The following is a description of a gene set: from publication Yevshin I, Sharipov R, Kolmykov S, Kondrakhin Y, Kolpakov F (PMID 30445619) Mouse Gene Set: MAFA_TARGET_GENES species: Mus musculus Genes containing one or more binding sites for (Mafa) in their promoter regions (TSS -1000,+100 bp) as identified by GTRD version 20.06 ChIP-seq harmonization., and this is the list of marker genes: Cbs, A630076J17Rik, Bcar3, Krit1, Tpr, Cfhr1, Uckl1os, Sgsm3, Mipep, Scn9a, AW209491, 4732440D04Rik, Plekhg1, Fam187b, Tm7sf2, Dtd1, Gm12180, Slc29a2 (NCBI Gene Id 13340), Usp31, Txnl4a, Nup107, Tspan4, Rwdd2b, Smarce1, 4933406C10Rik, Tbca, Fam133b, Gak, Ltbp4, Lrrk1, Zfp282, Utp3, Mapre3, Srl, Celf1, 2700068H02Rik, Kctd6, Rmc1, Gm20753, Ankhd1, Siva1, Trmu, Pole3, Dstn, Aars2, Agpat2, Tysnd1, Arnt, Dynlt2b, Mrtfb, 4833418N02Rik, Edem2, Gm17450, Map2k2, Gm10190 (predicted gene 10190), Ercc3, Tnks2, Prr13, Trmo, Cox18, Ptpru, Zfp963, Pcbp2, Aldh9a1, 2310033P09Rik, Herc4, Dgkz, Eef1d, Ewsr1, Slc35f5, mt-Tp, Itpk1 (NCBI Gene Id 217837), Dazap2, Gsn, Phlpp1, Eva1c, Eif3a, Trim29, Tanc2, Nop58 (NOP58 ribonucleoprotein), Ccdc112, Sar1a, Cnih4, Yes1 (NCBI Gene Id 22612), Apex1, Rnase4, Mir6236, Etv1, Ddhd2, Gm4890, Pde7a, Rps27l, Polr1b, Ctsf, Kctd12, Ccnj, Ndrg3, Itgb1, St8sia5, Prlr, Serinc3, Prdm1, Ccdc88a, Atg2a, 4930598F16Rik, Tmed2, Scrn3, Gm9955, Sri, Denr, Nkiras1, Kbtbd7, Creb1, Fbxl12os, Tppp3, Cggbp1, Memo1, Sertad2, Slc45a4, Phf2, Pde7b (NCBI Gene Id 29863, phosphodiesterase 7B), Txlng, Garnl3, Uts2b, Lrp2bp, Rpl21, Nsmce2, Pskh1, 4930563E18Rik, Mtpap, Xrcc4, Mrps24, Mir3971, Synrg, Ninl, Lmo7, Bcl7a, Ppp4r4, Phospho2, Clk4, Specc1l, Mkln1os, Cdkn2c, Axin2, Stag2, Slco1a4, Fam168b, Chmp4b, Adnp, Nr6a1, Med8, Nrep, Dhodh, D630024D03Rik, Wdr7, Ap2a2, Nfkb1, Mrpl48, Suco, Cnnm3, Rnf157, Mrps33, Fam171b, Hes1, Setd5, Mier1, 9330111N05Rik, Sypl1, Kmt5b, Gm17484, Srebf1, Gm14488, mt-Ts2, Wdr5, Acat2, Septin10, Gzf1, Vps37b, Rnu11, Mlf1, Enc1, Cd47, Rev3l, Tyms, Ptpn3, Gna11, Per1, Rabggtb, AW822252, Alad, Ptprd (protein tyrosine phosphatase receptor type D), As3mt, Rps5, Plscr3, Alkbh2, Rpl22l1, Cmc1, Chaf1b, Gpr146, Gm14963, Gm12758, Llgl2, Nbeal1, Gars1, Mrnip, 0610040B10Rik, Tnrc6b, Ggct, Mynn, Manf, Stk3, Tbpl1, Sowahc, Agl, Kat6a, Dyrk1b, Kiz, Gm7160, Gcc2, Abhd4, C2cd4c, Kntc1, Rchy1, Serp1 (NCBI Gene Id 28146), Brpf1, Snx32, Myo6, Syndig1l, Ttc7, 4933430I17Rik, Pde10a, 2500004C02Rik, Aph1b, Fyn, Ube2f, Cryba2, Kcnab2, Gart, B130034C11Rik, Ccdc127, mt-Th, Gm4285, Ppp2r3a, Fam210b, Phlpp2, Lhx1, D030040B21Rik, Papss1, Aamdc, Kdm2a, Mepce, 1810055G02Rik, Gm7071, Ankrd16, Mcc, Zfand3, Nr2f6, Atl1 (NCBI Gene Id 73991), Znhit2, Gm22203, Rpp25, Pptc7, Tnpo1, 1700019D03Rik, Xrcc3, Pdxdc1, Tmem104, Arrdc3, Mtcl1, Gm11821, Edf1, Mipepos, Bhlhe41, Caprin1, Lsm14a, Arl13b, Trp53inp2, Mir132, Scaf4, Bcl10, Tmed3, 2010320M18Rik, Ins2, Shisal1, Phlda3, Thoc7, Sgo2a, Dnm1, Golga5 (golgin A5), Wrnip1, Snx10, Zbtb7b, Tcea2, Clcn3 (chloride channel, voltage-sensitive 3), Mta2, Cul4b, Gm17399, Eapp, Fbrsl1, Cpne8, Ctxnd1, Nfatc2ip, Prrc2b, Psmg2, Erbin, Rnf128, Rpl37a, 4933417E11Rik, Pigq, Cdk5rap2, Etv5, Mir5130, n-R5s194, Kbtbd8os, Bach1, Faim, B230317F23Rik, Nsd3, Phtf2, Ttc39b, Serbp1, Galc, Mirlet7i, Klf5, Nsa2, Fam117b, Styxl1, Cgn, Mecomos, Gm30648, Birc2, Ttc34, Gins2, Dtnb, Ccdc88c, 1110020A21Rik, Peli1, Zfp652, Foxa2, Psmd5, Ssbp1, Atp1a1, Xpot, Prdx1, Ccdc186, Bcr (BCR activator of RhoGEF and GTPase), Aldh4a1, Ddx5, Adck1, Atxn7l3b (ataxin 7-like 3B), Gt(ROSA)26Sor, Ankib1, Sirpa, Polr2l, Tmem42, Ago2, Rab33b, Atp6v0a1, Fpgs, B3galt2, Chid1, Lonp2, Mex3b, Shprh, Tspan14, 4933427D14Rik, Mir5133, Rbl2, Snx5, Rb1cc1, Arf6 (NCBI Gene Id 11845), Mrpl2, Prob1, Rnft2, Cacnb2, Puf60, 2500002B13Rik, Chd6, Trerf1, Tmem147, Ift46, Mgme1, Zfp213, Snx3, Arl3, Ss18l2 (SS18, nBAF chromatin remodeling complex subunit like 2), Lamp1, Tcp11l2, Cdk12, Ergic1, Unc50, Gale, Ankrd12, Rad51b, Dusp23, Kdm5b, Jpt2, Anapc10, Adam10, Adgrg1, Pgls, Cnrip1, Josd2, Gm34086, A830018L16Rik, Cirbp, Gm32950, Cpm, Nat9, Mir3069, Gm37885, Stambpl1, Tubgcp2, Cinp, Med30 (NCBI Gene Id 70303), Asl, 1700023H06Rik, Gm5113, Slitrk6, Osgin1 (oxidative stress induced growth inhibitor 1), AI480526, Wfs1, Ythdf2, Rell2 (NCBI Gene Id 70794), Rab6a, Cabp1, Uckl1, Zcchc2, Snord70, Nr4a1, Dnai1, Mrm1, Icmt, Ube2ql1, Flvcr1, Idh2, Slc16a6, Spring1, Secisbp2, H4c1, Slx4ip, Mmaa, Gopc, Scrt1, 2310026I22Rik, Mir9768, Nop2, Rpl21-ps3, Golga4, Iapp, Gm37254, Kdm3a, Coro2b, Coasy (Coenzyme A synthase), Add3, Psmd1, Dennd4b, Aifm1, Trap1, Mapk8, Rasd1, Anapc16, Abce1, 1700069B07Rik, Eaf2, Zcwpw1, Malat1, Lrrc8b, Ndufaf8, Fam229b, D930007P13Rik, Dagla, Osgep, Dnajc3, Gm10244, Rps3a1, Map4k4, Rrm2b (ribonucleotide reductase M2 B (TP53 inducible)), Pabir1, Gm15545, Slc10a7, Ass1, Zfp740, Lifr (NCBI Gene Id 319661), Fosl1, Smarcc1, Casc3, Pgrmc2, Mvk, Lpin1 (NCBI Gene Id 50494), Gm12762, Tlcd4, Nanos1, Zfp426 (NCBI Gene Id 72998), Il13ra1, Dnpep, Rtn4, Irgq, Spryd3, Pgs1, Map2k4, Erg28, Tmem106c, Upf1, Fhit, Rapgef1, Txnrd1, Exosc3, Rpl14, Ehd3, Eif4e, Tcf4, Epc1, Sesn1, Sbf2, Rnf139, E2f4, Snx11, Mir215, Nlrp4b, Mrs2, Creg1, Sf3a2, Nol12, Hmbox1, Snord45c (small nucleolar RNA, C/D box 45C, NCBI Gene Id 100217425), Ica1, Crebrf, Kif5c, Tmem167b, Id4, Akt2, Macrod2, Hspd1 (NCBI Gene Id 15510), Cherp, Chst12, App, Zkscan2, Slc35e1, Ttll5, Nsun3, Arhgap26, Fam114a2, Ctsl (cathepsin L), Cep95, Prmt3, 4933406I18Rik, Pspc1, Lcorl, Atg5, Strada, Eif4b, Zfp235, Otud6b, Gm26306, Rsrp1, Mmab, Pde4dip, E230016M11Rik, Rpl9, Elf2, Oxld1, Prpf40b, Mfap3l, Msantd5l, Yipf6, Mtmr6, Bicdl1, Poc1b, Fstl3, Cdc37, Gm17344, Hspe1, Pusl1, Wipi1, Cpeb4, Sphkap, Dnai4, Reep2, Swi5, Mecr, Macir, Tex261, Bcl2l11, Eif3d, Zfp146, Ubr2, Ccnl2, Txndc11, Lasp1, Mafb, Gng5, Hapstr1, Jtb, Bod1l, Ubr4, Rcan1, Mob1a, Foxo6, Nutf2, Pik3r1, Tmem138 (transmembrane protein 138, NCBI Gene Id 76664), Polr3e, Mettl15, 1700007L15Rik, Cep85, Aff1, Ipp, Washc5, Nanp, Cdc73 (NCBI Gene Id 96910), Csn3, Cbx3, Rhoq, Gm15564, Kpna3, Pabpc1, Kif18a, Fads2, Nptxr, Fnbp1l, Gnb1, Zbtb7a, Tsc22d2, Snx30, Rad23a, Ppp3r1, Exoc5, Gm11251, Trim46, Mgat5, Gm17435 (predicted gene, 17435), Plcb1, Pom121, Ascc2, Ints9, Map3k4, 4931406C07Rik, Tsc22d1, Krtcap2, Cfap418, Cdc42bpb, Iqgap2 (IQ motif containing GTPase activating protein 2), Spen, Ky, Stag1, Sema6d, Jup, Gm15816, 4930480C01Rik, Map4k5, Actr3, Rtn3, Mllt3, Lacc1, Rpl15, Ccdc122, Eloc, Spata31e2, Gcsh, Cltc, Pja2, Spcs3, Per2, Srrm2, Atp1b1, Gm10961, Gm12915, Ascc1, 4732491K20Rik, Fmo1, Taf1b, Nsfl1c, Mcf2l, Rock2, Usp1, Cyth1, Ttc8, Skic8, Map2k7, 4930449I04Rik, Fam219a, Phf3, Bcl7b, Snip1, Ttpal, Phyhipl, Arhgap35, Entrep2, Ndor1, Lrrfip1, Pkdcc, Usf2, Cdca2, Tmem106b, Isl1, Urb1, Egln2, Tomm20, Adh1, Atp4a, Spaca6, Crcp, Ksr1 (kinase suppressor of ras 1), Rbck1, Mapk8ip2, Marchf3, Cacna1a, mt-Tl2, Lrba, Atxn2l, Capns1, Arf4os, n-R5s88, Sgsh, Atp5f1a, Tm9sf2, Mpv17l, Ncoa3, 2300009A05Rik, Plce1, Fras1, Tex2, Mars1, Eif2a (eukaryotic translation initiation factor 2A), Zdhhc4, Man1c1, Slain2, Gm16759, Hbp1, D130020L05Rik, Dgat1, Glb1l2, Oser1, Hsdl1, Cd164, Scg2, Qrich1, Csrnp2, Hacd3, Hadhb, Norad, Arpc2, Zfp62, Gm26123, Spast, Rab8a, Lss, Cyb5d1, Zfp335os, Ddx3x, Usp6nl, Ndufs4, Szt2, Ttc9c, Acap3, Alg2, Gdi2, Sugp2, Blmh, Fbxo7, Brd4, Gm22043, Herc1, Car7 (carbonic anhydrase 7), Lsr, Ahdc1, Hyi (hydroxypyruvate isomerase (putative)), Ppp1r8, Bsg, Usp32, Mettl21a, Snhg15, Comtd1, Zfat, Dhcr24, Rdx, Gm4189, Gm19409, Cyp51, Ccser2, Rfc5, Rai14, Atad2b, Lrp12, Gm16364, Rogdi, Zbtb2, Ypel3, Lactb2, Adrm1, Sfxn2, Acin1, Zfp318, Msl2, Snora9, 4933408N05Rik, Naa38, Tmem203, Ttll13, Col2a1, Ap5m1, Lmna, Cnot6, Gm10222, Samd4, Cdk4, Polr3h, Laptm4b, Rara, Ctnna3, Pbx3, Coa5, Gfm2, G6pc2, D5Ertd579e, Gpcpd1, Dip2c, Dipk2a, Mapkap1, Nudt9, Tlcd3a, Zc3h14, Pdxk-ps, Tube1, Ube2e3, Rab23, Mir148a, Txndc17, Nphp4, Ptov1, Phf13, Shld2, Tdrd7, Foxj2, Ccnh, Rock1, mt-Nd5, Stat5a, Arhgap22, Timm22, Camsap2, Ube2e1, Psmc5, Tigd5, Fbh1, Dennd4a, Dnaaf1, Armc6, Tph2, Cog2, Dtwd2, Rnf170, Ap5b1, Mir423, Gm12711, Gm24175, Dazap1, Spg7, Wtap, Ftsj3, Tipin, B4galt7 (beta-1,4-galactosyltransferase 7), Gm37450, mt-Nd6, Ost4, Tspan15, Fgd1, Taf1d, A330035P11Rik, Gm9967, Nme4, Gpd1l, Zfp768, Hibadh, Ero1b, A930006L05Rik, Slc15a4, Cep76 (NCBI Gene Id 76151), Rimoc1, Hnrnph3, Arf3, Arf4, Gm16283, Yif1b, Rgs7, Abhd3, Ptprj, Ociad1, Cspp1 (NCBI Gene Id 72327), Aup1, Rab3gap1, mt-Te, Srsf2, Hdac3, Eid2b, Capn7, Preb, Rimbp2, Oxr1, 6030458C11Rik, Mphosph8, Dock8 (NCBI Gene Id 76088), Osbpl5, Sec61b, Nipsnap2, Setd3, Hnrnpf, Vapb, Plbd2 (phospholipase B domain containing 2), Hsf4, Trmt13, Tasor, Cdc37l1, Vps29, Elmo2, Snord37, Nt5c3, Uchl5, Zdhhc20, Rplp2, Tepsin, Coq10b, Spry4, Sdha, Lyplal1, Gpsm2, Gm15860, Tmem131l, Fgl2, Arsa, Tmem170, Pip4p1, Spata1, Lpcat3, Fam83d, Gm15417, Midn, Stard3nl, Tmem147os, Mkrn1, Syne2, Glce, Tm2d2, Tbc1d16, Ulk2, Gm9929, Map3k7, Trp53i13, Ro60, Abhd2, Cers6, Agbl5, Abcg1, Gpr12, C330013E15Rik, Gins3, Ang, Plekhj1, Gm26293, Pkn2, BC043934, Golgb1, Emc1, Lrrc20, Pik3r2, Alkbh5, A430078I02Rik, Mxd1, Zfp653, Piezo1, Otud1, Npr1, Dnaja1, Psma3, Kmt2a, Rab3gap2, Nkx2-2 (NCBI Gene Id 228734), Mir30a, Usp2, Tor3a, Kif20b, Gm15728, Rwdd1, Zdhhc21, Limk2, Ghitm, Zfp398, Cul2, Odr4, Ing5, Slc33a1, Atf6, Htra2, Taf12, Hopx, Tbk1, 2900093K20Rik, Naglu, Ehd1, Pdcd2, Impdh1, Xpc, Son, Ppp2r5d, Lsm3 (NCBI Gene Id 70029), Kir3dl2, Gm25794, Glud1, Apba1, Pnrc1, Zbtb24, Gprin1, Fam222a, Ppp6r3, Cnih1, Mdh2, Hrh3, Hadha, Nsmaf, Rbpj, Mecom, Itgb5, Arhgap39, Gm10421, Tbcc, Ablim1, 1700010B13Rik, Nr1h4, Prmt9, Srsf11, Mfsd14a, Kdsr, Zfand5, Mideas (mitotic deacetylase associated SANT domain protein), Zfp839, Zfp764l1, Snapc3, Vgll4, Limch1, Ccdc137, Gtf2h1, Bcap31, Gnl2, Patz1, Zfp637, Ss18l1, Polr2b (polymerase (RNA) II (DNA directed) polypeptide B), Hook3, H4c8, Rufy3, Zfp148, Hsp90aa1, Dcun1d3, Kdm3b, Atad3a, Btrc, Atp6v1b2, Saysd1, Esco1, Gm15712 (predicted gene 15712), Mcrs1, Cfap97, Tead1, Rbbp6, Baz2b, Sgo1, Exoc4, Wdsub1, Ap1g1, Gm8357, Fos, Dnajc14, Gm10614, Spsb4, Prl7a1, Commd1, Fhod3, E130307A14Rik, Bbc3, Cyb561a3, Nsun4, Smim1, Syncrip, Ccne1, Ercc6l2, Slain1, Csnk1d, Atp8a1 (ATPase phospholipid transporting 8A1), Naa12, Pla2g6, Rad9b, Galk2, Marchf7, Rpl21-ps7, Rhbdd3, Tmtc2, Mfsd6l, 4931414P19Rik, Papola (NCBI Gene Id 18789), Slc35a1, Chd2, Dnali1, Mcl1, C230037L18Rik, Aarsd1, Mapk9, Atg16l2, Eif2b5, Noa1, Cyth3, Cct8 (chaperonin containing TCP1 subunit 8), Zfyve26, n-R5s211, Gtf2h2, Arid1a, Qdpr, Mkks, Pou2f1, Ccdc40, Trp53i11, Trim11, Vezt, Vps8, Tfg, Mtfr1l, Tada1, Ankle2, Pepd, Rhobtb1, Tmem175 (transmembrane protein 175), Gdpd5, 9130401M01Rik, Pdik1l, Hps5, Vapa, Pcid2, Tob1, Spr-ps1, Msh2, Dpy19l1, Alcam, Nhlrc3, Rbmxl1 (RNA binding motif protein, X-linked like-1), Skil, Trim2, mt-Tt, Adgrf4, Gm2093, Opa3, Eif4enif1, Kctd15, Notch2, Atp6v1c1, Mlh1, Mfap3, Myef2 (myelin basic protein expression factor 2, repressor), Shb, Arfgef3, Mrpl39, Vangl2, Tpt1, Fbxo47, Mrto4, Ptk2b, Etv6, Grhl3, Mafg, Sde2, Proser1, Acbd4, Slc26a11, 4930524O07Rik, Thap6, Gm13726, Ins1, Mfsd11, Msto1, Nsrp1, Gm40190, Spata6, Apbb2, Cir1, Zfp592, Drosha, Pcmtd2